The following is a description of a gene set: Abnormal circulating homocysteine concentration Human Gene Set: HP_ABNORMAL_CIRCULATING_HOMOCYSTEINE_CONCENTRATION species: Homo sapiens An abnormality of a homocysteine metabolic process., and this is the list of marker genes: ABCD4, MCEE, CD320, AHCY, SLC19A1, MMACHC, TCN2, MTHFR, MTRR, CBS, HCFC1, MMADHC, LMBRD1, PRDX1, NFE2L2, MTR, MTHFD1